The following is a description of a gene set: species: Homo sapiens The process in which relatively unspecialized cells acquire specialized structural and/or functional features that characterize the mature cells of the hindbrain. Differentiation includes the processes involved in commitment of a cell to a specific fate. Human Gene Set: GOBP_CELL_DIFFERENTIATION_IN_HINDBRAIN, and this is the list of marker genes: FAIM2, LHX5, OPHN1, LDB1, RORA, GATA2, LHX1 (LIM homeobox 1), WNT7A, AGTPBP1, TTC21B, KNDC1, FOXP2, NRXN1, SKOR2, PHOX2B, GRID2, CBLN1, TTLL1, PROX1, HERC1, ATP7A, CEND1, NOG, SLC25A46